Given this list of marker genes RAB14, MYO7A, TMEM175, RAB20 (RAB20, member RAS oncogene family), RAB34 (NCBI Gene Id 83871), RAB39A, CLN3, RAB7A, SPG11, VPS33B, P2RX7, RAB7B, ARL8B, PIKFYVE, PLA2G5, SRPX, VIPAS39, SYT7, CORO1A, here is a description of the gene set: Human Gene Set: GOBP_PHAGOLYSOSOME_ASSEMBLY The process that results in the fusion of a phagosome, a vesicle formed by phagocytosis, with a lysosome. studied in species Homo sapiens